The following is a description of a gene set: A secondary ossification center in the phalanges of the hand that is distinct from the normal epiphysis that does not contribute to the longitudinal growth of a tubular bone. species: Homo sapiens Human Gene Set: HP_PSEUDOEPIPHYSES_OF_THE_PHALANGES_OF_THE_HAND Pseudoepiphyses of the phalanges of the hand, and this is the list of marker genes: KCNH1, GDF5, BMPR1B, NPR3, RAB23 (RAB23, member RAS oncogene family)